Given this list of marker genes Naa60, Apoa1, Pdf, Metap2, Apoa2, here is a description of the gene set: Mouse Gene Set: GOBP_PEPTIDYL_METHIONINE_MODIFICATION The modification of peptidyl-methionine. species: Mus musculus